Given this list of marker genes E2F1, CDK2, E2F3, CCNA1, CCNA2, here is a description of the gene set: Human Gene Set: REACTOME_G2_PHASE species: Homo sapiens G2 Phase